Given this list of marker genes KHDC4, CFL2, ELAVL4, SLC38A1, HECW2, EIF2S2, PSD3, TFB1M, RPL26L1, ERBIN, DEPDC4, GTPBP3, FOXN3, RAB11A, CCNL1, TES, MED27, TENM4, DCAF10, RHOQ, THAP5, RBMS1, FNDC3B, VPS36, C3orf52, MSL3, KMT2E, SPIN1, IGFBP3, NKX3-1, GRIN3A, LRCH2, WASF3, ZNF148, RNF186, PRSS23, CEP350, FREM2, BICD2, CASZ1, KLHL15, ATXN7L3B, JCAD, ACAP2, NKAPD1, SLC17A6, CDH2, CP, HDX, ANK3, SMAD5, MSL2, CCDC34, GNA13, UGCG, NAALADL2, ELFN2, SLITRK4, MRPL35, PTGS1, FUT9, EPS15, WDFY3, ZEB2, XYLT1, PDE4D, TET3, BNIP2, UHRF2, GCOM1, LDB3, PURB, ZNF772, SRBD1, PDIK1L, NAPB, ADAMTS5, SLC39A14, ZNF598, SEPTIN8, MAP2, RMND5A, MARCHF2, SHANK1, JADE1, CCAR1, XDH, PUM1, PIK3R1, PAIP2B, TMEM47, MTF1, FNIP1, SCAF11, RAB21, PLCB1, EMSY, OPRM1, PHTF2, GIMAP7, TCF24 (NCBI Gene Id 641383), KLF4, AHNAK, DENND4C, ZNF516, CLXN, SH3TC1 (NCBI Gene Id 54436), TMEM9B, RHOBTB3, PSMA2, GSPT2, SPTLC2, GIT2, ABLIM1, PLS1, CR1, PMFBP1, ZBTB33, PUS7, MAP3K20, AGO4, DLG2, GLS, ZMYND11, MEMO1, SLC9C1, CDH4, ITGB8, GABRA4, PAK5, RHAG, GMNC, GPR85, ATXN7L3, ANKRD11, C1orf174, SMAD4, DLK1, DLX5, UBE2D3, SCAF8, NIN (NCBI Gene Id 57681), KCTD8, PRDM2, USP33, FBXW11 (F-box and WD repeat domain containing 11), GAREM1, CBX6 (NCBI Gene Id 23466), EGR4, ZNF367, KIAA0319L, CCNK (NCBI Gene Id 8812), NADK, MFSD6, PCDHGA7, ARFIP1, MALL, STAG2, ANKRD44, CBFB, G0S2, LSM12, TRIM66, JAKMIP1 (NCBI Gene Id 152789), RAP1A, EPHA5, TMEM170B, TNPO1, GNAI3, SIX4, CNEP1R1, PACRGL, HCFC2, HAUS8, LRRFIP1, KLHL21, DPM1, NWD2, GXYLT1, POLR2M, PAX3, ANKRD6 (ankyrin repeat domain 6), RAMAC, FAM199X, BRWD1, PWWP3B, CREBRF, CREBL2, CTNNB1, NEXN, ZDHHC21, ACTL6A, PLXNA4, ATF2, POC1B-GALNT4, FAM43A (NCBI Gene Id 131583), CLEC3B, SLC30A4, TMED5, CDC42, KLK12, GPC5, B4GALT5, B3GNT2 (UDP-GlcNAc:betaGal beta-1,3-N-acetylglucosaminyltransferase 2), SLC35A3, THRB, MPRIP, GEM, FBXO32, KIF5B, ETV6, VGLL4 (vestigial like family member 4), ZNF483, DNAAF9, PIK3CA, EBF1, STRN, KLF7, ROR1, IL1R1, MAN1A1, SLC2A13, CDYL, DENND11, NUP58 (NCBI Gene Id 9818), HNRNPK, TFRC, CBR4, ZNF140, EIF2D (eukaryotic translation initiation factor 2D), GPATCH2L, EZH2, PPP1R15B, KCNA4, FRYL, GALNT2, SIPA1L1, VAPA, FAM76B, RAB38, HMGA2, RCE1, RICTOR, RNLS, NR2C1, PDS5A, SCN9A, ACBD5, DCK, PHLDB2, DCP1A, HNRNPR, HSBP1, GHITM, BTF3L4, MBNL3, SRD5A1, GSPT1, CDH7, SLCO3A1, RFX7, POLR3F, MAEA, PLEKHA8, CNKSR2, STK26, FNBP4, RASSF5, THSD7A, PBRM1, PPM1B, ANKRD46, PFKFB4, YAE1, ATG14, GPR158, PARP4, KPNA4, MAMDC2, UBN1, LHFPL2, CAVIN2, INSIG1, ELOVL5, GALNT4, PPP2R5E (NCBI Gene Id 63385), NCOR1, SP4, GLIS3, SUZ12, PPTC7, TBC1D31, SOX9, ZAR1L, RGPD4, TENT4B, RCN2, CLIP1, TRIO, FSTL1, ARHGEF7, HOXA9, HELZ, QKI, TNRC6B, OTUD1, SENP2, HOOK3, SFRP2, CACUL1, ZDHHC20, ANO4, DMXL1, LYPLA1, CABLES2, MAT2B, NUDT11, METTL8, NRXN1, SAMD8, ACSL6, SLAIN2, ZBTB18, RBMXL1, NCKAP5, NOXRED1, TENM1, CAB39, C1GALT1C1, C6orf89, SALL1, FBXO8, MEF2A, TP53TG3C, MYBL1 (MYB proto-oncogene like 1), POU2F3, USP47, ING3, SPTSSB, ENDOD1, HSPA9 (NCBI Gene Id 91471), SNX16, MXRA5, MACROH2A1, MEF2C, USF3, GCC2, PRMT8, ZNF84, NAA25, RAB23, DMD, RAP2C, PYHIN1, KCNB2, EPAS1, TMEM196, MAPK8, TRIM2, PRPF39, SLC4A7, CD47, JAK2, FILIP1L, UBE2I, USP13, TP63, ARMC1, RBM46, PTAR1, PALD1 (NCBI Gene Id 27143), BCL6, ATP8B1, SPON1, ANKFY1, PRKAR2B, GABRA1, ESR1, VIT, S1PR1, MAFB, NUP54, TENT2, SORBS1, AKIRIN1, MICAL2, E2F8, TGFB3, SUCO, LRRC39, ITSN2, TSC1, SGCB, SEC24A, SCN3A, HFM1, MIER1, SPMAP2, CNTN1, RNF111, SDC2, TP53TG3D, LCOR, RSPO2, NR3C2, FRMD4B, TMEFF2, ZMAT3, CEP55, CSMD2, MRTFB, CTDSPL2, FOXJ2, CGGBP1, CSPP1, TMCC3, GUCY1A2, RIMS2, ADH1B, TBCEL, IL12B, FAM168B (NCBI Gene Id 130074), ATF7IP, SPART, IL17A, ZNF681, AUTS2, ZNF80, MDM4, BMP3, NFASC, KCNJ2, PCSK6, LRP2, RBMS2, WIZ, SPTBN4 (spectrin beta, non-erythrocytic 4), EOGT, GABRA5, BNC2, KMT5A, MAPK6, CSMD1, SLC1A6, KCNQ5, UBQLN1, PLSCR1, ARHGAP28, CAMK2G, MGAT2, WDR45B, TP53TG3, MED12L, CHIC2, TLL1, PLAA, PCDH7 (NCBI Gene Id 90855), CLOCK, ECT2, GOLPH3, OCLN, ELK4, AAK1, HIPK3, HIPK1, UBN2, DBN1, ZNF37A, KCNJ3, PDE5A, TSHZ3, CAND1, SV2B, ROBO1, ZNF135, PFKFB3, DDHD2, IGF2BP2, MSANTD3-TMEFF1 (NCBI Gene Id 100526694), POLH, TAOK1, NTS, TRUB1, LRRN1, PAX9, PHIP, FBXO9, SYPL1 (NCBI Gene Id 6856), PLK4 (polo like kinase 4), MSN, HLA-E, PRKCI, RARG, ATP6V1B2, ZNF273, DENND1B, SMURF2, KDM2B, TMEFF1, PITPNA, FAM117A, PRDM16, TRIM33, CNOT6L, NUDT15, SLC30A5, CCDC179, PDZRN3, ADGRA2, ROBO2, ASAP2, OTOGL, TP53TG3B, CAMSAP1, MID1 (midline 1), CLCN3, CTNND1, C11orf96, BPTF, SNIP1, OR9Q1, NEDD9, BTBD7, HOXA3, C1orf141, PDCD6IP, BMPR2, CYLD, PPP6C, LRP6, GPC6, ZNF713, MMP24, CAMK2N1, YEATS2, RBM33, SREK1IP1, NEBL, GRM7, INO80D, CPNE4, AMMECR1, FAM13B, EDARADD, SGK1, ZBTB41, CCNC, TEAD1, MB21D2, SECISBP2L, GINS4, LCLAT1, SENP1, DTX2, PBX3, TNFRSF19, CNOT7 (CCR4-NOT transcription complex subunit 7), VPS35, CHST1, SPOPL, MRPL44, SPOP, WDR44, PDPN, CLIP4 (CAP-Gly domain containing linker protein family member 4), VAMP4, MYNN, ALG9, ARB2A, AS3MT, NAV3, COX7A2L, ELFN1, SPTY2D1, SYN3, ELOC (NCBI Gene Id 6921), FAM168A, ALKAL2, PEX5L, LONRF3, ZNF534, PLXNA2, HOMER1, FUNDC1, API5, LRIG3, ADAMTS2, DLG5, KBTBD8, CNOT4, PTEN, LDLR, SOX6, ARHGEF3, LIMCH1, ARPP19, ANO1, STARD4, SSPN, AKT3, here is a description of the gene set: Human Gene Set: MIR548AW from publication Chen Y, Wang X (PMID 31504780) Genes predicted to be targets of miRBase v22 microRNA hsa-miR-548aw in miRDB v6.0 with MirTarget v4 prediction scores > 80 (high confidence targets). studied in species Homo sapiens